The following is a description of a gene set: Xenobiotics species: Mus musculus Mouse Gene Set: REACTOME_XENOBIOTICS, and this is the list of marker genes: Cyp3a59, Cyp2a22, Ahrr (aryl-hydrocarbon receptor repressor), Cyp3a41b, Cyp2d22, Cyp3a44, Arnt2, Cyp2a5, Cyp2w1, Cyp2c29, Cyp3a16, Cyp2a12, Cyp3a13 (cytochrome P450, family 3, subfamily a, polypeptide 13), Cyp2s1, Ahr, Cyp2b23, Cyp3a57, Cyp2f2, Cyp1a2, Cyp2c66 (NCBI Gene Id 69888), Cyp3a41a, Cyp3a11, Cyp2a4, Cyp1a1, Cyp2j6, Cyp3a25, Arnt, Cyp2c65, Cyp2e1